Given this list of marker genes TERF1, H2BC13, H2AX, H2BC12L, H2AC20, H2AC6, H2AZ2, TERF2IP, H2AC4, H2AC18, POT1, H2AC7, H2BC17 (NCBI Gene Id 8348), H2BC11, H2BC21, H2AJ, H2BC5, H2BC15, TERF2, H2BC14, H2AB1, H3-4, H2BC9, H2BC1, TINF2, H2BC4, H2AC14, ACD, H2BC12, H2BC3, H2BC26, H4C1, here is a description of the gene set: studied in species Homo sapiens part of: Telomere Maintenance Multiple steps, including C-strand resection, telomerase-mediated elongation, and C-strand synthesis are involved in processing and maintaining the telomere. Though this module posits a linear transit for the steps, in humans it is not well understood how these steps are coordinated and what other events may be involved.<br><br>Telomeric DNA can form higher order structures. Electron microscopy of telomeric DNA isolated from human cells provided evidence for lariat-type structures termed telomeric loops, or t-loops. t-loops are proposed to result from the invasion of the 3' G-rich single strand overhang into the double stranded telomeric TTAGGG repeat tract. The function of the t-loop is presumed to be the masking of the 3' telomeric overhang. Multiple protein factors can bind telomeric DNA and likely contribute to dynamic, higher order structures. Reactome Pathway: Packaging Of Telomere Ends